The following is a description of a gene set: from publication Jeffrey KL, Brummer T, Rolph MS, Liu SM, Callejas NA, Grumont RJ, Gillieron C, Mackay F, Grey S, Camps M, Rommel C, Gerondakis SD, Mackay CR (PMID 16474395) In the present study we used Affymetrix oligonucleotide microarrays to produce gene transcription profiles for the major leukocyte types in humans. This comprehensive dataset enabled us to not only establish which genes were expressed in each leukocyte type, but also which genes were expressed in each subset after activation. The used of a comprehensive dataset of gene profiles from all the major human leukocyte subsets enabled a novel and powerful means for identification of genes associated with single leukocyte subsets, or different immune paradigms. studied in species Homo sapiens Human Gene Set: GSE3982_MAC_VS_TH1_UP Genes up-regulated in comparison of macrophages versus Th1 cells., and this is the list of marker genes: CHD9, SLC6A12, WSB1, JHY, MMD, WWTR1, EEF1AKMT3, ENG, POLR3B, FAM131A, GNAQ, PXDC1, HOMER3, TXNRD3, DOP1B, CD68 (CD68 molecule), HMOX1, PROC, SQOR, LY75, DNAI2, CTNS, NTM, PPARD, FTH1, ERI2, KLF9, GATM, P2RY13, RTN1 (NCBI Gene Id 8108), HTRA1, RDH14, SCPEP1, IL5RA, SAMD4A, LRP1, SOS2, TNFRSF1A, PLAU, MTMR1, DPP8, MAPK1IP1L, CYSLTR2, EVI2B, CD84, CLCN7, YIPF1, RASAL2, LYSET, GALC, PHYH, USP12, FOLR2, TVP23B, ENOSF1, TMEM9B, ARHGAP24, RNASE2, TLN2, RC3H2, AP3S1, DEFA6, GNG12, SGSM2, TRDMT1, RUFY1, MAPK1 (NCBI Gene Id 5594), IFNA1, PMP22, DRAM1, BMP2K, CTSH, SAT1, DENND1B, SPRY2, MMP2, CALHM2, TLR4, SESN1, ITGAX, GPT, DACT1, PGLS, TP53TG1, RHEB, ENTPD7, TCTA, UBE2D1 (NCBI Gene Id 9335, ubiquitin conjugating enzyme E2 D1), TCEAL1, PLXNA1 (plexin A1), SERINC3, N4BP2L1, PSG9, CYFIP1, SP3P, CEP170, PPM1F, APLP2, CLIC2, TMX4, PLEKHF2, SDHD, CHMP3, TMX2, ARAP1, SLC2A5, EFR3A, SWAP70, ACE, IFNAR1, ATXN3, MYCL, IMPACT, RABGEF1, SNAP23 (NCBI Gene Id 8773), DEK, PHACTR1, SASH1, TUBB2A (tubulin beta 2A class IIa), UBXN2B, ATP2C1, KLHL24, COMMD8, VAT1, ZNF263, FCGR3B (NCBI Gene Id 2215), COMMD10, SIN3B, OSBPL8, CLN8, ACOX2, VNN3P, CD101, CREG1, SNX29 (NCBI Gene Id 92018), TMEM127, CCL8, FOXO3 (forkhead box O3), MYO6, ZDHHC7, HSD17B11, NDRG2, SOCS5, KCNJ1, VCL, TRIM13, EOGT, SLC25A24 (solute carrier family 25 member 24), HP, SLC22A18AS, C11orf71, ANXA9, DPPA4, VNN1, GCA, NAGPA, CEBPA, METTL22, TPK1, RGCC, SNX13, REPS2, MPC2, PIK3CB, KIF1B, SPAG9, ITGB3, SIDT2, RGS20, CCNT2, NFE2, DENND5A, HOXD3, AGO4, CES3, PLEKHO2, VAV3, LTBR, ITGAV, MARCHF8, SCG5, TMED7, EYA4, PAPOLG, BMS1P20, GRM6, ACBD3, TUBA1A, FYCO1, FOLH1B, ANXA4, ARHGEF17, CD14, CLOCK, ZHX3, RADX, OGFRL1, FCN1, TACSTD2